Given this list of marker genes PPP2R1A, NUP85, RPS6KA3, KPTN, RNF125, HIRA, B3GAT3, TGFBR1, ZEB2, LMNA, TPO, RBBP8, HESX1, FGFR1, HDAC4, SH2B1, ARID2, PDPN, CHD4, ERCC5, MEG3, CDC45, RECQL4, LRP5 (LDL receptor related protein 5, NCBI Gene Id 8058), NEK1, TOMM7 (NCBI Gene Id 54543), NLRP3, LUZP1, ALX4, CTCF, IL11RA, NOTCH3, FBXL4, RREB1, SCUBE3, ADARB1, SMAD3, PPP1R21 (NCBI Gene Id 129285), WDR19, DNA2 (DNA replication helicase/nuclease 2), APC2, SCARF2, ANKRD11, UBAP2L, SLC39A8, TGFB2, CHD5, GPC6, GLIS3, ATP6V1B2, GJA1, SMG9, CCBE1, RAC3, CCDC134, ZNF699, CARS1, ALPL, CEP152 (NCBI Gene Id 23701), SNX10, ADAMTS3, DUOXA2, LEMD2, GLI3, LHX4, PEX1, AARS1 (NCBI Gene Id 16), TENT5A, MTX2, USP7, ADSL, NSUN2, WBP4, DLK1, KCNQ1, PRIM1, CDH11, AHDC1, TLK2, ERCC3, CREB3L1, TNFSF11, SEC24D, AASS, TCF12, INTS11, CYP2R1, MSX2, HPGD, FKBP10 (NCBI Gene Id 60681), PYCR1, OTUD5, PCNT, FOXG1, AGTR1, ABCC8, COL1A2, KMT2D, WDR35, MAN2B1, ESCO2, GP1BB, INTU, AGT, IL6ST (interleukin 6 cytokine family signal transducer), ERCC6, IFT52, SON, TAPT1, CHST14 (carbohydrate sulfotransferase 14), FAM111A, SMC3, DPH1, GRB10, NAA10, RTL1, SPEN, B4GALT7, CEP120, PDX1, PPP1CB, JMJD1C, WNK1, RNU4ATAC, GMNN, SLC12A6, KCNQ1OT1, NOTCH2, H3-3B (NCBI Gene Id 3021), ALDH18A1, ZFX, CRTAP, GORAB, FLNB, KDM4B, HERC1, IPO8, TBX1 (T-box transcription factor 1), SMAD6, ERCC2, TMEM38B, SP7 (NCBI Gene Id 121340), DONSON, IRX5, HSD17B4, ATP6V0A2 (ATPase H+ transporting V0 subunit a2), DNMT3A, GPC4, MAP1B, FAM20C, NSD1, AGO2, CYP27B1, MESD, CWC27, MMP23B, NSRP1, IFITM5, SETD1A (SET domain containing 1A, histone lysine methyltransferase), CCNQ (cyclin Q), GH1, H4C9, COLEC11, KIF1A (kinesin family member 1A), LTBP1, POGZ, SEC24C, HNRNPU, CDK8, CENPE, KDM5B, TGFB3, PTDSS1, BICRA, ASPA, GPC3 (glypican 3), TCIRG1 (T cell immune regulator 1, ATPase H+ transporting V0 subunit a3), IYD, IFT43, RBM10, FBLN5, PEX19, NFIA, PRKG2, KCNJ11, SLC2A10, MMP14, ARVCF, BCL11B, PRKCZ, RETREG1, BPNT2, SLC25A24, SC5D, HNRNPK, FBN1, CLCN3, LHX3, B3GLCT, KANSL1, COL1A1, ACE, PRDM16, CAMSAP1, IGF2, CREBBP, PLOD2, RPS19, PEX2, AMER1, ATR, FGFR2, GTF2H5, NCAPG2, TRAIP, TG, GJA8, MYH3, CRELD1, SLC4A10, GNPTAB, TRAF7, ELN, SKI, AFF4, EP300, LMX1B, IFT122 (NCBI Gene Id 55764), PLK4, PSAT1, STXBP1, IFT140, CDKN1C, DDX6, ANTXR1, CEP57, H19, MAP3K7, ACTB, GJA5 (NCBI Gene Id 2702), CDC6, TRPV6, RSPRY1, ATP7A (NCBI Gene Id 613259), EFNB1, COMT, MEGF8 (NCBI Gene Id 90198), TCOF1, TOGARAM1, SEC23A (NCBI Gene Id 353367), LIG4, KCNAB2, TMEM216, ERI1, CASZ1, ADAMTSL1, FREM1, CYP26B1, SLC35A2, RERE, PIGT, PURA, DPH2, ENPP1, MMP2, SPECC1L, ZIC1, PCDHGC4, ERCC1, ZNF292, ORC6, ALG9, REN, RTTN, CHST3, AIFM1, EXTL3, DIAPH1, COL11A1, YY1, ASXL1, PPIB, PPP3CA, PHEX, SH3PXD2B, ROR2, SETBP1, POLR3A, MED12, VAC14, SMO, AKT1, SRCAP, SCN9A, SLC5A5, ACTG1, DMP1, NARS2, TBCK, ORC1, DCHS1, HUWE1, MASP1 (MBL associated serine protease 1), MPLKIP, EXOC8, RNU12, COLEC10, PROP1, KRT14, PAM16, P4HB, SIX2, RUNX2, BANF1 (barrier to autointegration nuclear assembly factor 1), THRA, ORC4, FAT4, CTSK, RAB23, BMP1, GTF2E2, MAPK1, SLC34A3, TBCE, PPFIBP1, FGFR3, SMARCD1, ATRIP, POLR1A, FIG4, ADAMTS2, PIGA, TANC2, B3GALT6, ZMPSTE24, DDB1, NUP188, DPF2, ASXL3, DSE, VDR, PTCH1, STAT3, ATIC, GCK, POLA1, PDGFRB, TWIST1, TBC1D24, PEX14, CDT1, RNU4-2, UBE4B, KAT6A, ZNF462, ATP6V1E1, FBXO11, TMCO1, MID1, CLCN7, SMAD2, EIF4A2, ERF, UFD1, KDM6A, POU1F1, TSHB, DUOX2, ATP6V1A, HSPG2, GNPNAT1, KRAS, MAF, KRT5, P3H1, NFIX, INS, PIGO, GABRD, TARS1, POR, FLNA, EBF3, BMP4, ERMARD, RNF113A, TGFBR2, KDELR2, here is a description of the gene set: Any anomaly of a cranial suture, that is one of the six membrane-covered openings in the incompletely ossified skull of the fetus or newborn infant. Human Gene Set: HP_ABNORMALITY_OF_CRANIAL_SUTURES studied in species Homo sapiens Abnormality of cranial sutures